The following is a description of a gene set: Genes in the cancer module 560. studied in species Homo sapiens Human Gene Set: MODULE_560, and this is the list of marker genes: MIR4453HG, SYN3, ALDH3A2, SERPINI1, SLC27A4, BAZ1B, UGT8, PMP22, PDE3B (phosphodiesterase 3B), GTF2H2, SRXN1, ATL2